The following is a description of a gene set: Mouse Gene Set: GOBP_CANNABINOID_SIGNALING_PATHWAY species: Mus musculus A G protein-coupled receptor signaling pathway initiated by a cannabinoid binding to its receptor on the cell surface, and ending with the regulation of a downstream cellular process, e.g. transcription. Cannabinoids are a class of diverse chemical compounds that include the endocannabinoids and the phytocannabinoids., and this is the list of marker genes: Cnr1, Abhd6, Gpr55, Cnr2, Camk2a, Mgll, Alox8